The following is a description of a gene set: studied in species Homo sapiens The series of molecular signals generated in response to diverse stress stimuli required to restore cellular homeostasis. The core event in this pathway is the phosphorylation of eIF2 alpha by one of four members of the eIF2a kinase family (EIF2AK1/HRI, EIF2AK2/PKR, EIF2AK3/PERK and EIF2AK4/GCN2), which leads to a decrease in global protein synthesis and the induction of selected genes, including the transcription factor ATF4, that together promote cellular recovery. Human Gene Set: GOBP_INTEGRATED_STRESS_RESPONSE_SIGNALING, and this is the list of marker genes: AKT3, CREBZF, NCK2, PTPN2, CREB3, HSPA5, MAP3K20, BATF3, NFE2, ABCA7, QRICH1, EIF2AK3, ATAD3A, NFE2L2 (NFE2 like bZIP transcription factor 2), MAF, AGR2, BATF, TMED2, MAFB, FOSL1, CEBPG, CEBPB, GCN1, CEBPD, EIF2S1, AKT1, PTPN1, DELE1, PPP1R15A, JUNB, DDIT3, IMPACT, RPAP2, TMEM33, NFE2L3, BOK, AKT2, ARIH1, NCK1, CEBPA, BATF2, EIF2AK1, JUN, HERC5, CEBPE, OMA1, ATF4, DDRGK1, PPP1R15B, FOS, EIF2AK4